Given this list of marker genes SUB1 (NCBI Gene Id 10923), LAMB1, PEG3, MYO1D, SPARC, GLRB, TRAF3IP2, SOD2, DLD, CTPS1, IMPACT, RCN1, THRA, SLC4A4, VLDLR, TIMM9, IRS2, MMP9, ETFBKMT, ENPEP, TIMP3, AMOTL2, MYO1B, WASHC3, CTBP2, MT1E, MAP2K3, NFKBIZ, CPE, FAM171A1, PPIH, NUDT19, DSG2, MRPL39, NR6A1, CPEB1, SPTBN1, LY75, CHGB, PKHD1, IFIT1B, TWF1, EFNB2, CTF1, COL5A2, PAWR, RYR3, SLC44A1, CPT1A, CISH, NAV2, GOLIM4, CX3CL1, PLEKHA7, CAPRIN2, CHIC1, BIRC2, TMPRSS2, SERPINB4, WWC1, CDKL2, EPCAM, SERPINB9, IRGM, TP63, FDX1, DAZAP1 (NCBI Gene Id 26528), CDIP1, SLCO5A1, CD200, CBX6, RSRP1, FBXO15, CCN1, ZNF106, ZWINT, MSC, GHR, SLC6A8, CDV3, ATP2A2, HSPA8, BPGM, CA14, SDHAF2, PBX1, GGPS1, SCMH1, ALCAM, TWSG1, MFSD4A, LIMCH1, ERRFI1, HOXB4, HSP90AB1, TOM1L1, RPA2, ANK3, CYB561, SYNJ2, SERPINB5, FOXN1, LPAR1, TGFB3, SIX1, CLIP4, CFL2, CXCL2, PMS2, SMIM11, CYP1B1, COMMD9, LIPC, CFAP418, THBS2, SIX2, CASP12, NDUFA5, ETNK1, INHBB, GEM, DEFB4A, PPIC, ADSS2, FAM83H, MLLT11, ELOVL6, SC5D, STC2, BMPR2, SQLE (squalene epoxidase), PACS1, BAIAP2L1, SCIN, GNA11, DLL1, GJA1, PLEKHA5, GCLM, HDLBP, HOXA1, MYO6, IL1R1, TPST1, LPP, NCKAP1, SDC1, CASP4, MED10 (mediator complex subunit 10), EHHADH, TUG1, EPS8, BMPR1A, HLA-DMA, ITGA3, CDC42EP4, FGG, BSDC1 (NCBI Gene Id 55108), GNAI1, EPB41L4B, TRDMT1, KPNA1, GJA4, DNAJB4, LMO4, TINAGL1, BOK, HSP90AA1, SKIC8 (SKI8 subunit of superkiller complex), PENK, ADGRG1, MAP7 (microtubule associated protein 7), CYP7B1, TP53INP2, HGSNAT, AMOT, EPRS1, GJA10, TXNDC17, LIMA1, BRCA1, RCBTB1, RRAS, TXNIP, TSC22D1, TOMM20, GIPC2, USP15, TMEM62, ST3GAL6, CHPF, RETREG1, PDK3, WLS, SLC1A4, F11R, FZD4, ARMCX2, LMO7, NPNT, here is a description of the gene set: In this study, we have investigated the effect of BLIMP1α on gene expression, cell differentiation and pathogenesis in normal human GC B cells using a non-viral vector based system from publication Vrzalikova K, Vockerodt M, Leonard S, Bell A, Wei W, Schrader A, Wright KL, Kube D, Rowe M, Woodman CB, Murray PG (PMID 21411757) Genes down-regulated in germinal center B lymphocytes: control versus over-expressing PRDM1. species: Homo sapiens Human Gene Set: GSE27670_CTRL_VS_BLIMP1_TRANSDUCED_GC_BCELL_DN